Given this list of marker genes FABP5, FUCA1, RUVBL1, STOML2, G3BP1, CYRIB, GTF2A2, PLXND1, PKD2, PSMC2, CHMP4A, RBX1, ARF3, HTATSF1, SEC14L1, LPL, ATP6V1A, ABHD3, TNS3, HTR3A, CASP2, CLSTN1, AP3S1, HMCES, MDH1, LDHB, CCL4, TFEC (transcription factor EC), UIMC1 (NCBI Gene Id 51720), GPR137B, METAP2, ARPC1B, HSBP1, STX7, SRRT, CCNF, BCL6, BAZ1B, TMEM126B, NBR1, PPP4C (NCBI Gene Id 5531), CDCA8 (NCBI Gene Id 55143), SMPDL3A, TOP1, RFC1, OSBPL9, SLC35A5, SERF2, NAA60, CD14, KIF15, NDUFA4, EPRS1, PSMC1, CFL1, MRPL15, MSH6, CD38, NDUFS6, COTL1, STAG2, PSMA7 (proteasome 20S subunit alpha 7), P2RX3, SEPHS1, CD27, SON, RWDD1, PSMD14, MRPL35, IFT25, PDIA6, SNRNP200, SRM, NUBPL, NDUFV1, SUMO2, DEK, ALDH2, ILK, SNRPG, RPA1, POLR3E, NUTF2, MCM10, PSIP1, COA3, ADA, DUT, HMMR, SPAG5, SMC4, DUSP9, EIF4E2, HIVEP3, FIRRM, KIF11 (NCBI Gene Id 3832), PSMB2, RAD17, H2AZ1, DPYSL2, SERBP1, SPC25, SAC3D1, MSRB2 (methionine sulfoxide reductase B2, NCBI Gene Id 51648), ENO2, MED14, CD81, CISD1, PSME2, DTL, MAP1S, HNRNPM, HERC2 (NCBI Gene Id 8924), MYO1E, CDK2AP2, SNRPD3, MAGEF1, DENR, NT5DC2, RASGRP1, DHRS7B, UBE2C, ADAMDEC1, NUP93, CHCHD2, ACTR2, SUGP2, MRPS33, SCFD1, BARD1, PSMA2, CAD, SDHC, MCTS1, SKIC8, DPY19L4, ILF2, USP7, NUCKS1, CDC6, NUP37, CBX1, MRPL22, MACROH2A1, ICMT, ANP32B, ATXN10, IDH2, IRAG2, PTPN7, ST14, TMEM258, PHB2, KIFC1, SDHB, CSNK1A1, RBBP7, TXNDC9, CSTB, AARS1, RACGAP1 (NCBI Gene Id 94651), ANXA2, DNAJC7, HPRT1, UQCR10 (NCBI Gene Id 29796), PTTG1 (PTTG1 regulator of sister chromatid separation, securin), TERF2, PFKM, PSMB8, POLA1, ETFA, IPP (intracisternal A particle-promoted polypeptide), DNAAF5, ORC1, SAE1, TRIB1, CMAS (cytidine monophosphate N-acetylneuraminic acid synthetase), TMA7, KIF4A, COX5A, OAZ2, ATP2A2 (NCBI Gene Id 488), H2AZ2, MRPS16, AIFM1, TFDP1, DCPS, SLC43A3, APIP, VAMP8, PSMA4, MCM7 (NCBI Gene Id 4176), RFWD3, ATP5PD, ANKHD1, MRPS31, GTF2E2, EIF3J, FBXO5, ATOX1, here is a description of the gene set: Genes down-regulated in comparison of naive B cell versus pre-germinal tonsil B cells. from publication Longo NS, Lugar PL, Yavuz S, Zhang W, Krijger PH, Russ DE, Jima DD, Dave SS, Grammer AC, Lipsky PE (PMID 19023113) Human Gene Set: GSE12845_NAIVE_VS_PRE_GC_TONSIL_BCELL_DN studied in species Homo sapiens B cells from human tonsil and blood were sorted using flow cytometry. The human samples were processed immediately ex-vivo using markers for known B cell subsets.